Given this list of marker genes SNAP25, SNORD116-1, HRAS, UBAP2L, SNORD115-1, AFF4, SIM1, ASXL1, CNBP, NFIX, LRRC32, DCTN1, SLC32A1, GRHL3, NALCN, ASNS, NDUFS2, HNRNPC, GRIN2A, ADRA2A, TSPYL1, DPH1, FGFR3, SIN3A, DDB1, C2CD3, P2RY11, ACBD6, CACNA2D1, IQSEC2, OCA2, USP7, TRPV4, HLA-DQB1, ARSB, HEPHL1, NGLY1, PCGF2 (NCBI Gene Id 7703), TGFBR1, COQ2, EP300 (E1A binding protein p300), LRPPRC, CTSH, MYT1L, FXN (frataxin), DPH2, HERC2, MRPS34, CACNA1I, PLCB4, NDN, GPR101 (G protein-coupled receptor 101), GUSB, MCM3AP, TNFSF4, PABPN1, TNNT1, TCF4, LARP7, CCDC47, DKK1, CACNA1C, P4HTM, FLII, CDK13, COL3A1, ABCC9, VPS51, FXR1, SYT2, CHAT, SNRPN, CTSK, PHOX2B, PRNP, NADK2, ATP1A2, DPH5, AGRN, UNC80, SYT1, UBB, IDS, SLC18A3, HCRT, CRELD1, RAI1, RECQL4, ZNF365, GRIN1, NACC1, IDUA, MAGEL2, ZNF462, ARCN1, NEFH, COLQ, CA2, CHAMP1, SLC25A1, NONO, ZFX, EXOC2, PWAR1, MKRN3, PRKAR1B, AIP (aryl hydrocarbon receptor interacting protein), SOX9, SPOP, GABRG2, CTNNB1, NOTCH3, CAPRIN1, FBXO28, MED27, PIGT, TERT, BRAF, EDN1, SLC5A7, ZBTB7A, PRR12, RNH1, CDC42BPB, LTBP3, NPAP1, MYO9A, BICD2, CREBBP, DMD, SRPX2, HLA-DRB1, ASCL1, SOD1, PWRN1, BMP2, CEP57, RPS6KA3, DNA2, GSN, RAB11B, ZMYM2, NAA80, SH3BP2, NCAPG2, VAMP1, RERE, POGZ, PRPS1, DEAF1, GNAI3, GNPTAB, FLCN, RUNX2, SKI, DVL1, H4C5, COL13A1, NDUFAF2 (NADH:ubiquinone oxidoreductase complex assembly factor 2), EXT2, SATB2, ARL3, ATN1, PRPH, PRMT7, MUSK, GNE, AHDC1, FGFR2, TWIST1, MOG, RET, ASCC3, GRB10, NUP54, LAMB2 (laminin subunit beta 2), here is a description of the gene set: Conditions of abnormal and difficult respiration during sleep, including chronic snoring and sleep apnea. Sleep-related breathing disorders studied in species Homo sapiens Human Gene Set: HP_SLEEP_RELATED_BREATHING_DISORDERS